The following is a description of a gene set: Human Gene Set: WP_16P122_COPY_NUMBER_VARIATION_SYNDROME_520KB 16p12.2 copy number variation syndrome (520kb) studied in species Homo sapiens, and this is the list of marker genes: NDUFA9 (NCBI Gene Id 4721), MAPK1, EEF2K, TRPM7 (NCBI Gene Id 54822), RPS6KB1, MAPK11, MLST8, PRKAB2, RPTOR, PDZD9, COX5A, MAPK3, CYC1, RPS6KA1, MAPK12, UQCRC2, CALM2, UQCR11, MT-CYB (mitochondrially encoded cytochrome b), MAP2K2, PRKAA2, PRKAG1, UQCRH, UQCRQ, VWA3A, NDUFS3, MAPK13, CALM3, SDR42E2, CDR2, CDK2, UQCRFS1, MOSMO, MAPK14, NDUFA4, UQCRB, PRKAG2, NDUFV1, PRKAB1, UQCR10, CDK1, NDUFS8, UQCRC1, EEF2, MTOR, RAB5IF (RAB5 interacting factor), PRKAG3, CDH18 (NCBI Gene Id 64404), MAP2K1, COX7C, CALM1, TRAP1, POLR3E, PRKAA1